Given this list of marker genes NDUFS4, RDH11, PRPS1, MPDU1, COX6B1, OSTM1, ATP1A3, ZNHIT3, RAB3GAP2, here is a description of the gene set: Undetectable visual evoked potentials studied in species Homo sapiens Human Gene Set: HP_UNDETECTABLE_VISUAL_EVOKED_POTENTIALS